Given this list of marker genes Gas6, Ednra, Ednrb, Ctns, Cd2ap (NCBI Gene Id 98065), Adipoq, Rhpn1, Edn1, Comt, here is a description of the gene set: Mouse Gene Set: GOBP_RENAL_ALBUMIN_ABSORPTION species: Mus musculus A renal system process in which albumin is taken up from the collecting ducts, glomerulus and proximal and distal loops of the nephron.